Given this list of marker genes SCN3B, SCN2A, SCN11A, FXYD7, KCNA5, SCN7A, TNNI3, NKX2-5 (NK2 homeobox 5), CACNA1C, NPR2, CLIC2, ATP2B4, RYR2, FGF13, KCNK3, KCNE5, ATP2A1, ATP2A3, ATP2B2, CAMK2G, CALM1 (calmodulin 1), KCNK9, NPPA, FXYD4, PLN, ATP1A3, KCNIP2 (NCBI Gene Id 30819), CES1, SCN2B, CASQ1, SRI, CAMK2D, ATP2A2, SLN, AKAP9, KCNK16, KCNJ12, KCNK4, FXYD6, ATP1B1, SLC8A2, KCNK6, KCNK1, ATP1A4, SCN1A, ATP1A1, ITPR3, KCNK5, AHCYL1, HIPK2, CACNG4, NPR1, HIPK1, ATP2B3, ATP1A2, KCNK13, FXYD1, KCNH2, KCND3, KCNIP4, TRPC1, CACNB2, MME, CASQ2, FGF14, SCN10A, SLC8A1, KCNE1, RANGRF, FXYD3 (FXYD domain containing ion transport regulator 3), DMPK, ITPR2, KCNE2, KCNK18, SCN3A, KCNK7, NPPC, SCN4B, STIM1, CACNG8, CACNA2D2, ATP2B1, WWTR1, KCNQ1, KCNJ2, RYR1, SCN5A, KAT2B, KCNJ11, ABCC9, SCN4A, FGF11, CORIN, FGF12, KCNE4, CAMK2A, SCN1B, ATP1B3, FKBP1B, KCNK2, SCN9A, KCNK15, ATP1B2, ORAI2, SLC8A3, KCND1, KCND2, SCN8A, KCNJ4, TBX5, TRDN, PRKACA, KCNK12, ITPR1, KCNK17, FXYD2, CAMK2B, RYR3, KCNIP1, KCNJ14, CACNG7, GATA4, KCNE3, CACNG6, ORAI1, ASPH, KCNIP3, NOS1, KCNK10, CACNB1, here is a description of the gene set: part of: Muscle contraction studied in species Homo sapiens The normal sequence of contraction of atria and ventricles of the heart require activation of groups of cardiac cells. The mechanism must elicit rapid changes in heart rate and respond to changes in autonomic tone. The cardiac action potential controls these functions. Action potentials are generated by the movement of ions through transmembrane ion channels in cardiac cells. Like skeletal myocytes (and axons), in the resting state, a given cardiac myocyte has a negative membrane potential. In both muscle types, after a delay (the absolute refractory period), K+ channels reopen and the resulting flow of K+ out of the cell causes repolarisation. The voltage-gated Ca2+ channels on the cardiac sarcolemma membrane are generally triggered by an influx of Na+ during phase 0 of the action potential. Cardiac muscle cells are so tightly bound that when one of these cells is excited the action potential spreads to all of them. The standard model used to understand the cardiac action potential is the action potential of the ventricular myocyte (Park & Fishman 2011, Grant 2009).<br><br>The action potential has 5 phases (numbered 0-4). Phase 4 describes the membrane potential when a cell is not being stimulated. The normal resting potential in the ventricular myocardium is between -85 to -95 mV. The K+ gradient across the cell membrane is the key determinant in the normal resting potential. Phase 0 is the rapid depolarisation phase in which electrical stimulation of a cell opens the closed, fast Na+ channels, causing a large influx of Na+ creating a Na+ current (I<sub>Na+</sub>). This causes depolarisation of the cell. The slope of phase 0 represents the maximum rate of potential change and differs in contractile and pacemaker cells. Phase 1 is the inactivation of the fast Na+ channels. The transient net outward current causing the small downward deflection (the "notch" of the action potetial) is due to the movement of K+ and Cl- ions. In pacemaker cells, this phase is due to rapid K+ efflux and closure of L-type Ca2+ channels. Phase 2 is the plateau phase which is sustained by a balance of Ca2+ influx and K+ efflux. This phase sustains muscle contraction. Phase 3 of the action potential is where a concerted action of two outward delayed currents brings about repolarisation back down to the resting potential. Reactome Pathway: Cardiac conduction